Given this list of marker genes EVC2, BOC, GRK2, IQCE, ARRB1, IHH, ARRB2, SHH, SMO, CDON, EFCAB7, PTCH1, KIF3A, GAS1, CSNK1A1, DHH, DRC4, EVC, here is a description of the gene set: Activation of the transmembrane protein SMO in response to Hh stimulation is a major control point in the Hh signaling pathway. In the absence of ligand, SMO is inhibited in an unknown manner by the Hh receptor PTCH. PTCH regulates SMO in a non-stoichiometric manner and there is little evidence that endogenous PTCH and SMO interact directly. PTCH may regulate SMO activity by controlling the flux of sterol-related SMO agonists and/or antagonists, although this has not been fully substantiated.<br><br>PTCH-mediated inhibition of SMO is relieved upon ligand stimulation of PTCH, but the mechanisms for this relief are again unknown. SMO and PTCH appear to have opposing localizations in both the 'off' and 'on' state, with PTCH exiting and SMO entering the cilium upon Hh pathway activation. Activation of SMO involves a conserved phosphorylation-mediated conformational change in the C-terminal tails that destabilizes an intramolecular interaction and promotes the interaction between adjacent tails in the SMO dimer. In Drosophila, this phosphorylation is mediated by PKA and CK1, while in vertebrates it appears to involve ADRBK1/GRK2 and CSNK1A1. Sequential phosphorylations along multiple serine and threonine motifs in the SMO C-terminal tail appear to allow a graded response to Hh ligand concentration in both flies and vertebrates. In flies, Smo C-terminal tail phosphorylation promotes an association with the Hedgehog signaling complex (HSC) through interaction with the scaffolding kinesin-2 like protein Cos2, activating the Fu kinase and ultimately releasing uncleaved Ci from the complex. In vertebrates, SMO C-terminal tail phosphorylation and conformational change is linked to its KIF7-dependent ciliary accumulation. In the cilium, SMO is restricted to a transition-zone proximal region known as the EvC zone. Both SMO phosphorylation and its ciliary localization are required to promote the Hh-dependent dissociation of the GLI:SUFU complex, ultimately allowing full-length GLI transcription factors to translocate to the nucleus to activate Hh-responsive genes.<br><br><br> Reactome Pathway: Activation of SMO studied in species Homo sapiens part of: Hedgehog 'on' state